The following is a description of a gene set: Any process that results in a change in state or activity of a cell or an organism (in terms of movement, secretion, enzyme production, gene expression, etc.) as a result of a folic acid stimulus. Human Gene Set: GOBP_RESPONSE_TO_FOLIC_ACID studied in species Homo sapiens, and this is the list of marker genes: ENSG00000274276, NFKBIZ, EEF2, ASCL1, GPX1, CBS, MTHFR, FOLR1, FOLR2, BCHE